The following is a description of a gene set: studied in species Mus musculus Mouse Gene Set: chr15B1, and this is the list of marker genes: 5830426I08Rik, Gm19111, Mir7212, Gm35769, Gm46506, Basp1, Gm8472, Gm2824, Gm36642, 9430068D22Rik, Otulinl, Gm2803, Gm6576 (NCBI Gene Id 670226), Marchf11, Ank, Gm22810, Gm2862, Gm4824, Otulin, Gm8484, Mir3964, Myo10, Gm31458, 9230109A22Rik, Zfp622, Gm41279, Gm6330, Gm36899, Gm5468, Gm20555, Gm36147, Gm9891, Trio, Gm19883, Dnah5, Mir7117, Gm23903, Tiaf2, Fbxl7, Retreg1, 4930445E18Rik, B230362B09Rik